Given this list of marker genes BRCA1 (BRCA1 DNA repair associated), RTF1, CXCL8, RPS6, WASHC5, CBY1, PROZ, VAMP5, HPS5, NOLC1, SMARCA5, CMA1 (NCBI Gene Id 1215), RRAS2, PRPSAP1, PKN2, RGS1, PRKACB, PYGM (glycogen phosphorylase, muscle associated), GLIPR1, RPL7, HOXB7, ATP13A3, TTC1, IFIT1, UBE2L6, MUC5B, RCN2, DVL1, HIVEP1, OSMR, KYNU, IQSEC2, DLEC1, SNTB2, MDH1, TNFAIP1, RPL13P5, ELAVL2, ACSL1, RIPK1, TLR2, PBX2, DRD3, DYNLT1, CD36, IL1RN, ARR3 (arrestin 3), ITGA2B, ABCC10, SAMM50, TFE3 (NCBI Gene Id 8244), SPINT1, SLC4A7, CDK1, UQCRH, TM9SF1, PPP1R3A, ACVRL1, AIMP1, PANK3, GPC3, RFPL3S, SSBP1, VDAC3 (voltage dependent anion channel 3), ENPP2, ARSF, GRIK5, EFNB1, IRF1, CMAHP, CD163, ZBTB40, TIA1, XYLT1, PTPN7, CPB1, SP110, KARS1, SUSD5, SFRP4, SLC2A5, IL13RA1, PADI2 (NCBI Gene Id 11240), PGM1, RAP1GDS1, CD74, SFMBT1, SAP30, YIPF2, TCF15, CLOCK, ARPC3, CLDND1 (NCBI Gene Id 56650), NEDD8, IFT25, OPA1, REM1, NCKAP1L, SNRPF, LDHB, SEMA4D, TWIST1, PLAAT4, GPSM3, LAMB3 (laminin subunit beta 3), UCN, GHRHR, PLAU, MTF1, BNIP3L, SPINK4, ASL, HERC3, TAOK2, TIMELESS, NUP133, MRPL40, OVOL3, PROCR, RALB, MSR1, OVOL2, TAX1BP1, BCL2A1, GBP2, ADCY6, API5 (NCBI Gene Id 95494), GIP (gastric inhibitory polypeptide), ENTPD3 (NCBI Gene Id 956), OLFML2B, AMHR2, TENM4, NDUFS1, DNTTIP2, IL16, PMP22, FEM1C, CCL8, PEX2, BCL2L2, ERP44, FABP4, CTSK, OSBPL8, CTNNB1, HOXC5, EPB41L3, TDO2, RPE, MFAP2, SSB, THEMIS2, CDC42, SIT1, S100A13, TFRC, ID2, POLR2D, PARP2, MX2, LAMTOR5, IRF2, NR1D2, GNRH2, MS4A1, IRAK3, DIAPH1, DDHD2, PSMB7, INPP4B, SULT1B1, CLK2, TRIAP1, HSP90AB1, PNP, SF3A3, ST3GAL2, VDAC2, NOTCH3, RUNX1, RLBP1, PFDN1, PSMD1, CLK1, PTPN2, EIF4E2, PIAS1, PHC2, SLC7A7, TXNIP, MUC6, EEF1AKMT3, ZNF189, NDRG1, ATIC, PSMB9, SPOP, HSPA6, AURKA, here is a description of the gene set: studied in species Homo sapiens Human Gene Set: GSE360_LOW_DOSE_B_MALAYI_VS_M_TUBERCULOSIS_MAC_DN Genes down-regulated in comparison of macrophages exposed to 5 worms/well B. malayi versus macrophages exposed to M. tuberculosis. from publication Chaussabel D, Semnani RT, McDowell MA, Sacks D, Sher A, Nutman TB (PMID 12663451) Monocyte-derived dendritic cells (DC) and macrophages (MΦ) generated in vitro from the same individual blood donors were exposed to five different pathogens, and gene expression profiles were assessed by microarray analysis. Responses to Mycobacterium tuberculosis and to phylogenetically distinct protozoan (Leishmania major, L. donovani, Toxoplasma gondii) and helminth (Brugia malayi) parasites were examined, each of which produces chronic infections in humans yet vary considerably in the nature of the immune responses they trigger.